The following is a description of a gene set: Genes predicted to be targets of miRBase v22 microRNA mmu_miR_6238 in miRDB v6.0 with MirTarget v4 prediction scores > 80 (high confidence targets). from publication Chen Y, Wang X (PMID 31504780) species: Mus musculus Mouse Gene Set: MIR_6238, and this is the list of marker genes: Cdyl, Fam91a1, Ift70b, Pde1c, Pkia, Cryab (crystallin, alpha B), Scn1a, Bco2, Blnk, Camk2d (NCBI Gene Id 77170), Nob1, Sun3, Ppp4c, Hdac9, Zfp560, Rab27b, Trim32, Zfp957, Ssr2, Rnf44, Ubxn2a, Tmem9b, Col25a1, Klf10, Dock11, Mid2, Chil6, Fbxo43, Ebf2, 1600014C10Rik (RIKEN cDNA 1600014C10 gene), Cd93, Mettl14, Map2k1, Spsb4, Ndufs4, Vcan, Zfp628, Spry2, Tstd3, Slc9a1, Car2, Zfhx4, Rpp30, Zfp280d, Tmem184c, Ube2e1, Gde1 (glycerophosphodiester phosphodiesterase 1), Tfg, Sema7a, Scaf11, Soat1, Mettl9, Thsd1 (NCBI Gene Id 80649), Eln, Ank3, Ipcef1 (NCBI Gene Id 320495), Slfnl1 (schlafen like 1), Sh3glb1, Srek1 (NCBI Gene Id 404583), Irx4, 4930564D02Rik, B4galt3, Chfr, Colec12, Slc31a1, H2-M10.6, Shmt2, Hormad1, Mrpl48, Lsm14a, Rgs18, Lars1, Lrrk2, Rab11a, Gnas (NCBI Gene Id 78290), Apbb1, Oip5, Scfd1, Mgat4a, Ftcd, Adrm1, Vcpip1, Map4, Garre1, Ehf, Nexmif, Ap1g1, Krtap9-20, Grm4, Ccz1, Adgrf3, Mcph1, Ikzf2, Hmgb1, Vps72, Cabin1, Snrnp200, Col5a2, Vmn1r148, Atxn1, Arhgap12, Igfbp6, Zfp141, Ubap1, Gata4, Larp4, Lca5, Aktip, Gdf10, Spag9, Smgc, Hmgcr, Memo1, Ube2n (ubiquitin-conjugating enzyme E2N), Pfkm, Rffl, 2210408I21Rik, Clock, Agbl4, Rps6ka6, Ddx5, Adam17, Sfrp2, Car10, Prrc2c, Fgg, Nr2f1 (NCBI Gene Id 13865), Krt10, Btn2a2, Arl14ep, Gnb3, Ruvbl1, Ptgr2, Nudt3 (nudix hydrolase 3), Shprh, Mill1 (NCBI Gene Id 266815), Neb, Anln, Sparcl1, Evi5 (ecotropic viral integration site 5), Nabp2, Lipo3, Tbc1d15, Ap4e1, Pou2af3, Cemip2, Zfp622, Tmtc3, Clec12b, Ly9 (lymphocyte antigen 9), Tmem100, Krtap4-1, Anapc10, Znrf3, Slc4a4, Rab9, Senp8, Tmem59, Gm525, Odad2, Pdlim4, Man1a2, Rala, Ddit4 (DNA-damage-inducible transcript 4), Tinag, Ropn1, Cxxc5, Dclk1, Vwa7, Plk4, Hspa12a, Atf2, Ythdf1, Tmem134, Arhgap18, Arf4, Neu3 (NCBI Gene Id 50877), Qdpr, Rela, Rab31, Ptges3, Tsc22d2, Trappc11, Rad21, Sod2, Myh11, Trpc5os, Snx13, Cx3cl1, Fscb, Atg3, Samd8, Ube2q2, Cox6b1, Slc15a5, Ccn6, Plekhb1, Npc2, Pou4f1, Cabcoco1, Eml5 (echinoderm microtubule associated protein like 5), Prep